Given this list of marker genes ILDR2, NFKBID, SMAD6, KCNJ1, PPARGC1B, CERS1, GLRA1, COL25A1, MAP4K3, HOXD4, PTRH2, TAOK1, C6orf62, CCNT2, CAST, ZP1, MBNL1, BCAM, KAT5, DCUN1D3, JADE1, SLC44A1, DLL4, B3GALT2, SPEG, FNDC7, HCST, GNL3LP1, SIX1, IGF1R, GATA6, DERL3, ZHX2, VCAN, XRCC1, ZNF362, SEMA3D, KDM3B, TSC22D1, FOXP4, FAM222B, BARHL1 (NCBI Gene Id 56751), PLAGL2, MIR9-1HG, SLC6A13, COL2A1, NTN5, LRRTM1, PSD, EPB41L4B, PURA, PIEZO1, TRAF4, APOLD1, RIMKLA, CSRNP2, DUSP5, COLQ, PCBP2, KCNB1, KRTAP8-1, STAG2, TMEM25, NR2E1, CNNM2, GDF1, RELA, FAM78A, H3-3B, NLGN3, TLNRD1, KCNC3 (potassium voltage-gated channel subfamily C member 3), AMPD2, NUDCD1, DIS3L2, UHRF2, FBXO9 (NCBI Gene Id 26268), BAHD1, BTBD9, GRIA1, RALYL, BDNF, BRMS1L, PDGFB, HEY1 (NCBI Gene Id 23462), MMP9, CNBP, PANK1, HTR2C, NEUROD1, TBCC, OLIG3, TPI1 (triosephosphate isomerase 1), SPTBN4, LTB4R, SCML1, CHRFAM7A, APLP2, ANKRD1, PLD1, SLC30A2, NTRK2 (NCBI Gene Id 4915), PSMD12, DAAM1, USP9X, REPS1, PRDM1 (NCBI Gene Id 639), LHX6, ZNF516-DT, CX3CL1, SLITRK5, LYRM1, OVOL2, HSALR1, CATSPER3, TBL1X, NTRK1, ZNF32, LINC00649, ADRA1B, RBPJ, NIPAL3, MNT, RBMS1, CRYBG2, CHST11, ETS2, LOXL3, MLLT3, MAGED1, CACNA1G, RSRC2, CELF6, FAM135B, POFUT1, CADM2, RASGEF1B, ANKRD17, ELMO3, MITF, CHAT, RBM14, MYOT, PCYT2, TNNT2, KAT7, EXT1, RBM5 (NCBI Gene Id 10181), MORF4, GNAO1, PTPRJ, FGF11, NRG2, PITX3, CDKN2C, TPM2, MSANTD2, JOSD2, L3MBTL1, DCANP1, RASGRF1, PPP1R9B, TLCD4, PPP2R5B, SRPK2, PNOC, ANKRD11, KCNH6, SCMH1, TTPAL, WNT5A, EFEMP2, SELENOI (selenoprotein I), SRSF2, NOL4, GRB7, NLK (NCBI Gene Id 51701), KPNA1, ADGRB3, TAF5 (NCBI Gene Id 6877), ELL2, CCN1, VWF, EMX2, GNAS (NCBI Gene Id 82944), HAPSTR1, KLF5, MAGI1, OR2K2, DOK1 (docking protein 1), TCF7L1, LGI1, ADD3, DCT, POLD4 (NCBI Gene Id 57804), LIN54, SPOP, UBE2D3, KCNJ13 (NCBI Gene Id 619535), PTCHD1, CORO6, PALS2, GJD2, ARMCX3, ENHO, LRRFIP1, YTHDF2, FCHSD2, EPHA2, WNT10B, GAP43, SLC6A12, E2F3, THRA, TRIM8, LPCAT3, HFM1, DNAJB5, ARID1A, SESN3, NIPBL, VAX1, KNTC1, NCOA6, CHD5, MFAP5, EIF1, VMP1, SRRM4, ANGPTL1, GPR3, WWC1, SORBS2, HSD3B7 (NCBI Gene Id 80270), TGFB3, DENND6A, BLVRB, SLC12A4, SMARCD2, RBM47, C20orf203, STC1, KLF12, BMI1 (BMI1 proto-oncogene, polycomb ring finger), PCBP4, here is a description of the gene set: Genes having at least one occurrence of the motif CNNRCCCGCATD in the regions spanning 4 kb centered on their transcription starting sites. This matches the GCM1 transcription factor binding site V$GCM_Q2 (v7.4 TRANSFAC). studied in species Homo sapiens Human Gene Set: GCM_Q2